Given this list of marker genes Slc12a1, Slc12a3, Slc12a2, Slc12a4, Slc12a5, Slc12a7, Slc12a6, here is a description of the gene set: Mouse Gene Set: REACTOME_CATION_COUPLED_CHLORIDE_COTRANSPORTERS Cation-coupled Chloride cotransporters studied in species Mus musculus